The following is a description of a gene set: studied in species Homo sapiens Human Gene Set: WP_COMPLEMENT_SYSTEM Complement system, and this is the list of marker genes: F10, CR1, VTN, C7, PRKACA (protein kinase cAMP-activated catalytic subunit alpha), FGG, RPS19, CD46, ITGA2B, FCN2, SFTPA2, FPR1, CFH, LAMC1, SELL, C5AR2, C5AR1, C1QBP, SELP, MASP1, CD19, PLAUR, CFP, CFB, PROS1, TXN, CFHR2, FGA, ITGAX, VSIG4, F11, FCGR3A, FKBP2, ITGB2, ELANE, CLEC4M, GNA15, ARRB2, SELE, IBSP, DCN, WAS, ADM, F13A1, ICAM1, CD55, ITGA2, C6, LAMA5, C1S (complement C1s), SPP1, SFTPA1, PRNP (prion protein (Kanno blood group)), CD40, LAMB1, SELPLG, MBL2, C2, C9, CR2, CD93, FCER2, ICAM2, F12, C4A, FGB, C8A, CFI, THBS1, PLG, KLKB1, C4BPA, ALB, CPN1, PRKCA, CRP, ITGB3, SERPING1, CFHR4, CFD, APCS, LRP2, C3, GNAI3, GNAI2, C3AR1, MASP2, CALR, CSNK1A1, C5, CD59, PTX3 (pentraxin 3), FCN1, APOA1, TLR2, ADIPOQ